The following is a description of a gene set: Any process that modulates the frequency, rate or extent of the proteolytic cleavage of transmembrane proteins and release of their ectodomain (extracellular domain). Human Gene Set: GOBP_REGULATION_OF_MEMBRANE_PROTEIN_ECTODOMAIN_PROTEOLYSIS studied in species Homo sapiens, and this is the list of marker genes: TIMP4, ADRA2A, NRDC, SNX9, TIMP1, TSPAN17, IL10, TIMP2, IFNG, SH3D19, ADAM8, TNFRSF1B, IL1B, TNF, RGMA, SNX33, ADAM9, GPLD1, PACSIN3, TIMP3, APP, APOE, PTPN3, LRIG2, TSPAN15, TSPAN5, FURIN, ROCK1